The following is a description of a gene set: Prominent nasal bridge Anterior positioning of the nasal root in comparison to the usual positioning for age. studied in species Homo sapiens Human Gene Set: HP_PROMINENT_NASAL_BRIDGE, and this is the list of marker genes: TXNL4A, ZNF699, EBP, KAT6A, TCTN2, TAF6, H4C9, WDR37, ARL13B, BBS5, IPO8, SMC1A, TMEM237, BBS10, HMGA2, NPHP1, TCF4, HNRNPK, ARVCF, GATA4, ERCC1, CPLANE1, MKS1, CDK13, ZMIZ1, PIGW, RLIM, UNC80, NONO, TOGARAM1, INSR (NCBI Gene Id 3643), TOMM7, BBS9, ANKH, TRRAP, ZDHHC9, GPC4, RELN, ARX, GP1BB, SRCAP, MGAT2, SOX18, LEMD3, TBC1D20, ZNF335, SNAP29, TCTN1, CLIC2, NR2F1, TP63, RNU4-2, TMEM218, PGAP2, LMNB1, CHD5, COX4I1, HERC1, TRIM32, CEP295, TMEM216, TTC8, PRKD1, ZNF526, GALNT2 (NCBI Gene Id 2590), KIFBP, AHI1, ACTG2, MED12L, NHS, TNPO2, SIN3A, RAP1B, EDNRB, HIRA, WBP4, MECP2, OFD1, PDE6D, KIAA0586, PAK3, SPEN, DHPS, UFD1, CEP290, AFF2, SCLT1, BBS1, SDCCAG8, POLR1A, TRIO, FGFR3, ARL6, LZTFL1, EBF3, BCR, HDAC8, BICRA, CEP41, RTTN, NBN, TOPORS, ARL3, ZNF423, TEFM, RECQL, OTUD6B, MITF, ATPAF2, CFAP418, TGFB3, TMEM231, NEXMIF, INPP5E, MED13, TBX1, ERCC6, HSPG2, PAX3, RAC1, BBS2, MEIS2, CRKL, RARS2, CBY1, HIVEP2, PDGFRB, SUFU, ARMC9, JMJD1C, CKAP2L, GJA8, NDE1, TLK2, EXT2, TAF4, SOX10, ALX4, PCNT, CTCF, BBS12, KAT6B, MAPK1, UPF3B, IFT27, CDC42BPB (NCBI Gene Id 9578), FGFR2, TCTN3, SMAD4 (SMAD family member 4), EXOSC5, VPS13B, SCUBE3, PIGL, BBS7, XRCC4, DCAF17, SPECC1L, IGBP1, MIA3, KANSL1, RPGRIP1L, KDM5B, SEC24C, CEP152, BRCA1, NFASC, B9D1, KDM6B, COLEC11, DYRK1A, ORC6, SH2B1, NSDHL (NCBI Gene Id 50814), SF3B4, SEC23A, PGAP3 (post-GPI attachment to proteins phospholipase 3), IFT57, ECE1, CEP120, RAB3GAP2, TBCK, HYLS1, WARS1, ANKRD11, MED12, KATNIP, PUM1, BBIP1, FAM149B1, DOCK7, COMT, KIAA0753, SMS, NALCN, ASXL3, PMM2, SMC3, BBS4, PHF21A, MAPK8IP3, EDN3, TWIST1, B9D2, IFT74, PIGY, TMEM138, RB1, FBXO11, ASPH, CENPF, CEP19, SPRED2, KDM5C, SPOP, CC2D2A, KAT8, WDPCP (WD repeat containing planar cell polarity effector), PIBF1, STAG1, CSPP1, SATB2, TMEM67, ASH1L, MKKS, PCDHGC4, RECQL4, GJA5, ATIC, SPRTN, CASK, FBN1, IFT172, KIF7, BCOR, SCAPER, NSUN2, PIGV, PIGO, RREB1, ALG12 (ALG12 alpha-1,6-mannosyltransferase), CEP104